Given this list of marker genes Cdc42se2, Tmem141, Aplp2 (NCBI Gene Id 11804), Islr2, Tox3, Corin, Rhbdl3, Klf12, Dpp6 (dipeptidylpeptidase 6), D430041D05Rik, Atp10a, Rab4a, Srcin1, Spsb1, Zfp518a, Shc1, 6430548M08Rik, Pcdh10, Dtna, Usf2, Ehf (ets homologous factor), Mrps26, Dpf1, Ptgfr, Slc24a3, Klf9, Pcdh8, Cxxc5, Pnp2, Adamts3, Prmt5, Zfp275, Cep350, Fbln2, Vcan, Phf13, Pdk3, Palld, Zfp318, Adam7, Gtf2e1, Tmf1, Camk4, Dcun1d4, Rictor, AI593442, Grip1, Slc39a1, Mier3, Myorg, Mecp2, Ccdc177, 1110004F10Rik, Tanc2, Tcp10a, Pdik1l, Rapgef2, Errfi1, Atxn2, Mapk8ip3, Sp4, Nrg3, Spred1, 4930523C07Rik, St18, Zmym3, Cers6, Top2b, Glyctk, Ddx6, Lrp10, Pdap1, Disp3, Zfp37, Car2, Clk3, Slc49a3, Jrk, Mical2, Nudt5, Plekhf2, Adamts5, Lifr, Hibch, Fkbp10, Larp4, Klhl18, Wwp1, Thsd7a, Zfand5, Ark2n, Zfp831 (NCBI Gene Id 100043757), Nampt, B3gat1, Ank1, Elk4, Lgalsl, Slc35f1, Nhs, Ccdc102a, Afap1l1, Mat1a (methionine adenosyltransferase 1A), Caskin1, Fads1, Ttl, Nat8l, Bicd1, Mylip, Tac1 (NCBI Gene Id 68182), Retreg1, Bcl3, Plcxd2, Arhgef18, Adam22, Kdm2a (lysine (K)-specific demethylase 2A), Lrrc19, Lypd6b, Rassf2, Stk35, Ptprt, Tspan7, Tm9sf3, Sbf2, Kansl1, Smurf2, Cdc42bpa, Gata4, Mbd6, Scn4b, Fgf12, Pum2, Dido1, B4galt2, Pigq, Rbm3, Cgn, Bmp8a, Dync1i2, Fam78a, Celf5, Zzz3, Wbp1l, Epha8, St8sia5, Add2, Scamp2, Birc3, Pax2, Mysm1, Prkce, Rab1a, Nrk, Tenm3, B3gat2, Ankrd44, Abr, Fam229a, Phtf2, Mbnl1, Scai, Zfhx3, Lmln, Tmem132b, Gpc5, Bivm, Cdc14a, Dcbld2, here is a description of the gene set: Mouse Gene Set: MIR_6965_3P from publication Chen Y, Wang X (PMID 31504780) species: Mus musculus Genes predicted to be targets of miRBase v22 microRNA mmu_miR_6965_3p in miRDB v6.0 with MirTarget v4 prediction scores > 80 (high confidence targets).